The following is a description of a gene set: Any process that modulates the frequency, rate, or extent of excretion, the elimination by an organism of the waste products that arise as a result of metabolic activity. species: Mus musculus Mouse Gene Set: GOBP_REGULATION_OF_EXCRETION, and this is the list of marker genes: Corin, Edn1, Npsr1 (NCBI Gene Id 319239), Crhr2, Spx, Nherf1, Stc1, Ptger3, Drd2